Given this list of marker genes RAD52, POLE3, RAD1, H2BC14, PARP2, FEN1, TOPBP1, POLD4, RFC5, ERCC1, ATR, H2BC12L, PPP4R2, BABAM1, MDC1, ERCC4, NSD2, PALB2, POLH, ATM, RTEL1, H2BC5, CHEK1, NBN, RFC1, POLD1, RAD51C, ATRIP, SUMO2, PIAS4, POLE4, RPA1, SLX1A, POLD2, SEM1, RHNO1, RAD51D, RMI2, XRCC1, RPA3, H2BC11, RAD51AP1, H2BC9, EME1, POLE2, TP53BP1, H2BC26, UBE2V2, H2BC3, TIMELESS, CCNA2, PCNA (proliferating cell nuclear antigen), TOP3A, UBC, RNF8, RFC2, RNF168, UBB (ubiquitin B), SPIDR, BRCA2 (BRCA2 DNA repair associated), H3-4, FIGNL1, BRIP1, KAT5, UBE2N, DNA2, H2BC13, BABAM2, PPP4C, RAD50, XRCC2, H2BC12, MRE11, POLE, RMI1, LIG3, EME2, RPA2, RPS27A, RAD17, RBBP8, ABL1, RFC3 (replication factor C subunit 3), H2BC15 (H2B clustered histone 15), H2BC1, UBA52, POLK, H2BC17, CDK2, RFC4, SIRT6, GEN1, MUS81, BARD1, BRCC3, BRCA1, EXO1, H2AX, H2BC21, POLQ, FIRRM, RAD51B (NCBI Gene Id 5890), POLD3, RNF4, WRN, CLSPN, PARP1, HERC2, H4C1, SLX4, RAD9A, HUS1, XRCC3, RAD51, H2BC4, RAD9B, UBE2I, CCNA1, UIMC1, TIPIN, BLM, ABRAXAS1, LIG1 (NCBI Gene Id 3978), here is a description of the gene set: Reactome Pathway: Homology Directed Repair part of: DNA Double-Strand Break Repair studied in species Homo sapiens Homology directed repair (HDR) of DNA double strand breaks (DSBs) requires resection of DNA DSB ends. Resection creates 3'-ssDNA overhangs which then anneal with a homologous DNA sequence. This homologous sequence can then be used as a template for DNA repair synthesis that bridges the DSB. HDR preferably occurs through the error-free homologous recombination repair (HRR), but can also occur through the error-prone single strand annealing (SSA), or the least accurate microhomology-mediated end joining (MMEJ).<p>HRR and SSA share the initial steps that involve ATM signaling, formation of the so-called ionizing radiation-induced foci (IRIF), extensive resection of DNA DSB ends and activation of ATR signaling. In homologous recombination, 3'-ssDNA overhangs anneal with complementary sister chromatid strands. In SSA, 3'-ssDNA overhangs anneal with each other through homologous direct repeats contained in each overhang, resulting in deletions of one of the repeats and the DNA sequence in between the repeats during DNA repair synthesis.<p>Contrary to HRR and SSA, which both involve annealing of long stretches of highly homologous DNA sequences, MMEJ entails annealing of short regions of two 3'-ssDNA overhangs (up to 20 nucleotides) and is therefore more promiscuous and more likely to join unrelated DNA molecules. The error rate of MMEJ is additionally increased by the low fidelity of the DNA polymerase theta (POLQ), which performs DNA repair synthesis in MMEJ.<p>For reviews of this topic, please refer to Khanna 2001, Thompson and Schild 2001, Thompson and Schild 2002, Thompson and Limoli 2003, Ciccia and Elledge 2010.